Given this list of marker genes VESTAR, MORN3 (MORN repeat containing 3), SMG7, TRAK1, FAM111B, FCHSD2, ATP9B, NBN, STAG3L5P, IFNGR1, NIBAN3, MBOAT1, HMGN3-AS1, NAXE, KNSTRN, INTS3, RPPH1, TAF1A-AS1, DUSP15, PLEKHG5, CLK3, UQCC6, BAHCC1, WDR62, BMP3, CAMK2N1, NECAP2, ETS2-AS1, C19orf47, ISLR2, MGST3, LINC00589, CDC42BPA, THAP8, TMEFF2, KSR2, SCGB1D2, CLASP1-AS1, PARP2, TEDC2, CILK1, FOXA2, SNIP1, SART3, CAPNS1, RN7SL165P, SVIP, MCCC2, RGCC (NCBI Gene Id 730127), XXYLT1, TAF1A, STAT6, PLD3, ATP6V0E2-AS1, ZNF433-AS1, CAMKK1 (calcium/calmodulin dependent protein kinase kinase 1), CDKN3, STAG3L5P-PVRIG2P-PILRB, NCOA3, ATP6V0E2, ARL4A, SLC9A1, RNU4ATAC, here is a description of the gene set: Genes containing one or more binding sites for (ZNF548) in their promoter regions (TSS -1000,+100 bp) as identified by GTRD version 20.06 ChIP-seq harmonization. from publication Yevshin I, Sharipov R, Kolmykov S, Kondrakhin Y, Kolpakov F (PMID 30445619) studied in species Homo sapiens Human Gene Set: ZNF548_TARGET_GENES